The following is a description of a gene set: from publication Mata-Haro V, Cekic C, Martin M, Chilton PM, Casella CR, Mitchell TC (PMID 17569868) species: Homo sapiens Human Gene Set: GSE7768_OVA_WITH_LPS_VS_OVA_WITH_MPL_IMMUNIZED_MOUSE_WHOLE_SPLEEN_6H_DN An unresolved issue in immunology is the extent to which inflammatory effects are needed for robust T cell responses. In this study, mice were immunized by iv injection using either high toxicity lipopolysaccharide (LPS) or low toxicity monophosphoryl lipid A (MPL) as adjuvant. Six hours after iv immunization, whole spleens were harvested and gene expression was measured in unfractionated splenic populations of cells. The analysis indicated that the low toxicity adjuvanticity of MPL was associated with TLR4-mediated signaling that was biased to the TRIF branch of TLR4, while LPS generated balanced MyD88 and TRIF-associated outcomes. Genes down-regulated in spleens: LPS versus monophosphoryl lipid A., and this is the list of marker genes: OTUD5, PSMA5, FBXL3, HCN1, MLKL, SYPL2, RAP2C, ST18, PTPN2, TMOD3, LIMS1, FMR1, PGAP2, MAP3K8, PSMB10 (NCBI Gene Id 8138), GADD45A, IRAK2, EDN1, SVBP, NR3C1, HIVEP3, RNF145, PTGS2, CALCRL, ST7, RSBN1, SLC25A28, KBTBD2, TES, PRRC2C, CDC42EP2, UBE2F, DUSP4, TMEM67, SLC15A3, NOTCH2, MOCS1, TPST1, PPA1, OGFR, NFKBIB, HIVEP1, CCNYL1, HPS3, CLN5, GOLGA8A, H3-3B, ZC2HC1A, PTAFR, IRF2, TBK1, LGALS9, CD44, AIM2, LRRC51, KDM6B, MAPKAPK2, FBXO39, TLK2, GOLGA3, DLGAP4, NSD3 (NCBI Gene Id 54904), ISOC1, PCGF5, GVINP1, GSDMD, NUB1, ICAM4, WDR37, VASP, ICOSLG, KLF6, TNFSF9, TRMT61B, RNF2, IL15, USB1, PNRC1, CCDC50, MIER3, CTRL, CSRNP1, ABR, TCIRG1 (NCBI Gene Id 8845), KREMEN1, XKR8, TDRD7, POMP, PIK3R5, RAB20, SAP30 (Sin3A associated protein 30), KLF7, MYO10, ATXN7, SELL, USP25, PLAUR, FOXP4 (NCBI Gene Id 116113), DCN, MTHFR, IGSF9, MARCKSL1, SPEN, CASP1, BBX, CCDC88B (coiled-coil domain containing 88B), SCARF1 (scavenger receptor class F member 1), SLAMF7, HMCN2, PLSCR1, MARCHF5, TENT4A, RNF14, ZC3HAV1, OAF, PTTG1, C2, ANXA1, ZCWPW2, TNIP3, AIDA, PRKCD, KHNYN, FAM53C, PLEKHA2, MITF, PARP3, TMEM219, DTWD1, TMEM170B, RAB32, LRRC63, CCNJ, TXNDC9, RALGAPA2, NFKB1, SLC49A4, NPEPPS, PDCD10 (programmed cell death 10, NCBI Gene Id 9226), STARD3 (StAR related lipid transfer domain containing 3), LMO4, MAX, CCNL1, FOXP1, ALDH1B1, CD14, RC3H1, COX18, PPFIBP1, KRT27, OPTN, KAT2B, DUSP16, RAB10, SLC25A2, RNF34, MIR221, TLR3, CHMP4B, KCNA3, CHST15, ZFP36, IRGC, PNPT1, ATG9A, RASA4, SRGAP2, CLDN23, PI4K2B, HINFP